Given this list of marker genes ATP1A2, SLC23A1, SLC23A2, GCLC, GSTO1, SELENON, GSTO2, PON2, PON3, CLSTN3, ERO1A, SLC2A1, PON1 (NCBI Gene Id 5444), SLC2A3, here is a description of the gene set: Human Gene Set: GOBP_LACTONE_METABOLIC_PROCESS species: Homo sapiens The chemical reactions and pathways involving lactone.